Given this list of marker genes Actr2, Kpnb1, Actr3, Katnb1, Cenpe, Fmn2, here is a description of the gene set: The directed movement of chromosomes in the center of the spindle towards the spindle poles, mediated by the shortening of microtubules attached to the chromosomes. Mouse Gene Set: GOBP_CHROMOSOME_MOVEMENT_TOWARDS_SPINDLE_POLE species: Mus musculus